Given this list of marker genes Agxt, Gpt2, Agxt2, Dao, Gpt, here is a description of the gene set: studied in species Mus musculus Mouse Gene Set: GOBP_ALANINE_METABOLIC_PROCESS The chemical reactions and pathways involving alanine, 2-aminopropanoic acid.